The following is a description of a gene set: studied in species Homo sapiens The region at the end of the longest axis of a cylindrical or elongated cell. Human Gene Set: GOCC_CELL_TIP, and this is the list of marker genes: PI4K2A, SLC32A1, RGS7, DES, GRM6, LRIT3, PKP2, RDX, GNB5, RAB8B